The following is a description of a gene set: Genes down-regulated during epithelial to mesenchymal transition (EMT) induced by TGFB1 in the EpH4 cells (mammary epithelium cell line transformed by HRAS). from publication Jechlinger M, Grunert S, Tamir IH, Janda E, Lüdemann S, Waerner T, Seither P, Weith A, Beug H, Kraut N (PMID 14562044) Human Gene Set: JECHLINGER_EPITHELIAL_TO_MESENCHYMAL_TRANSITION_DN species: Mus musculus Epithelial-to-mesenchymal transition (EMT), a switch of polarized epithelial cells to a migratory, fibroblastoid phenotype, is increasingly considered as an important event during malignant tumor progression and metastasis. To identify molecular players involved in EMT and metastasis, we performed expression profiling of a set of combined in vitro/in vivo cellular models, based on clonal, fully polarized mammary epithelial cells. Seven closely related cell pairs were used, which were modified by defined oncogenes and/or external factors and showed specific aspects of epithelial plasticity relevant to cell migration, local invasion and metastasis. Since mRNA levels do not necessarily reflect protein levels in cells, we used an improved expression profiling method based on polysome-bound RNA, suitable to analyse global gene expression on Affymetrix chips. A substantial fraction of all regulated genes was found to be exclusively controlled at the translational level. Furthermore, profiling of the above multiple cell pairs allowed one to identify small numbers of genes by cluster analysis, specifically correlating gene expression with EMT, metastasis, scattering and/or oncogene function. A small set of genes specifically regulated during EMT was identified, including key regulators and signaling pathways involved in cell proliferation, epithelial polarity, survival and trans-differentiation to mesenchymal-like cells with invasive behavior., and this is the list of marker genes: PADI2, ATP1A1, THBS1, DUSP1, ZNF239, BCL6, NUMB, CDH1 (cadherin 1), PLK2, CCN2, FLNA, TGM2, KITLG, SAT1, TIMP3, ID4, EGR1, KLF2, TIAM1, FOS, CTSH, IRF6, MYH9, FZD8, CHKA, INMT, CA2, EGR2 (NCBI Gene Id 1959), ID1, JUP, FBP2, ARHGEF1, CTNND1, PC, F3, ITGB5, TSC22D1, PKP1, HMMR, NRP1, BMP4 (bone morphogenetic protein 4), EPCAM, TGFB3, ZFP36, ID2, KRT14, STAT5A, ACTN4, SGK1 (NCBI Gene Id 6446), GRB7, ATF3, SERPINB5, PRKCZ, ITPR1, AMD1, NNT, CYP2F1, BTG2, HMGA2, NR4A1, VAMP8, KLF10